The following is a description of a gene set: Galactose catabolism Human Gene Set: REACTOME_GALACTOSE_CATABOLISM studied in species Homo sapiens, and this is the list of marker genes: GALE, GALM, PGM1, GALK1, AKR1B1, GALT